The following is a description of a gene set: studied in species Mus musculus Any process that modulates the frequency, rate or extent of glial cell migration. Mouse Gene Set: GOBP_REGULATION_OF_GLIAL_CELL_MIGRATION, and this is the list of marker genes: Ccr2 (NCBI Gene Id 235692), Cers2, Csf1, Stap1, Trem2, Rras2, Grin1, Ptprz1, P2rx4, Efemp1, Bmerb1, Atp1b2, Lrp1, Rras (related RAS viral (r-ras) oncogene), Gpr183, Nf1, Cx3cl1, Cx3cr1, Crkl, Fubp1, Fas, Tiam1, Vim, P2ry12, Ntn1, Idh2